Given this list of marker genes Dbn1, Abi2, Farp1, Actr3, Sh3gl2, Rac1, Rock2, Srcin1, Wasf2, Arf1, Frmpd4, Ezr, Dbnl, Myh10 (NCBI Gene Id 77579), Sipa1l1, Arhgef7, Actn2, Cpne6, Nos1ap, Wasl, Adgrb1, Rac3, Ppp1r9a, Actb, here is a description of the gene set: Mouse Gene Set: GOBP_POSTSYNAPTIC_ACTIN_CYTOSKELETON_ORGANIZATION studied in species Mus musculus A process that is carried out at the cellular level which results in the assembly, arrangement of constituent parts, or disassembly of cytoskeletal structures comprising actin filaments and their associated proteins in the postsynaptic actin cytoskeleton.